The following is a description of a gene set: Human Gene Set: GSE41176_WT_VS_TAK1_KO_UNSTIM_BCELL_UP The activation signaling of transcription factor nuclear factor-kB (NF-kB) plays central role for immune system. One of key kinase mediating this pathway is TAK1 in adaptive and innate immunity. However, role of TAK1 in B cell receptor signaling is still unclear. To know effects of TAK1-deletion on the gene expression induced by anti-IgM, we performed the time course analysis in comparison of wild type with TAK1-deleted splenic B cells. Genes up-regulated in B lymphocytes: wildtype versus MAP3K7. from publication Shinohara H, Behar M, Inoue K, Hiroshima M, Yasuda T, Nagashima T, Kimura S, Sanjo H, Maeda S, Yumoto N, Ki S, Akira S, Sako Y, Hoffmann A, Kurosaki T, Okada-Hatakeyama M (PMID 24833394) studied in species Homo sapiens, and this is the list of marker genes: TOM1L2, HOXA11, ADGRG1, PPP2CA, SEC14L3, NTRK1, SH3GL1, NDST4, PODXL, TJP2, SNCG, IP6K1 (inositol hexakisphosphate kinase 1), ARID5A, ACSL6, PCDHA6, MAP3K8, VAPB, SPRR1A, SZRD1, RPS14, PTGDS, ALCAM, SRPK3, TOE1, SRD5A2, BID, MUC2, UBE2H, SMS, DNAJC8, SIPA1L1, CAMP, RPL13, SNN, ECE1, INSIG1, PPP1R15A, BCL2A1, NPY4R, CALCOCO2, HLA-DQB2, MIA, ARFGAP3, TLK2 (tousled like kinase 2), KCNK7, CLK3 (CDC like kinase 3), NHERF4, TICAM1 (TIR domain containing adaptor molecule 1), LIME1, JAM3, CDC42EP2, BTG2, AMACR, AVP, STK19, NOP53, WTAP, ENDOD1, TRIB3, CNN1, BACH1, GPR37L1, ATF4, EREG, RNF2, GBP2, USP12, NR4A3 (NCBI Gene Id 8013), TNFAIP6, KMO (kynurenine 3-monooxygenase), PTTG2, LYPD3, AKT3, JOSD1, KANK1, CD69, SLC38A3, GMIP, TENT5C, TFF2, CHD5, PSEN1, EMD, ULBP2, ZNF394, RBP3, KLHL1, SPON2, NR4A1, ANKLE2 (NCBI Gene Id 23141), IST1, SF3B4, CLCN2, NFKB2, ZBTB17, TP53BP1, HOMER2, DNTT, TPSG1, DNASE1L2 (NCBI Gene Id 1775), SOD2, EDC3, ATF7IP, CHD4, RNF126P1, DNTTIP2, BMP6, TNFAIP8, TBX1, GCH1, ORC1, TPRA1, RRAGC, VASP, EFNA2, INCENP, DBN1 (drebrin 1), NRTN, ZFAND3 (NCBI Gene Id 60685), NINJ1, LILRA4, RAPGEF2, RELA, RBBP8, ZP2, AQP9, KBTBD2 (NCBI Gene Id 25948), TSPYL2, CLIC4, CDK17, CRYBB3, LTK, RAP2C (RAP2C, member of RAS oncogene family), FZD9, C10orf95, AKIRIN1, PCDHGA9, AEBP1, LINC00115, RAB5A, RPL35A, RPL24, RPS13, TAGLN2, CHST7, GJB5, SLC22A17, IGHG1, TNIP2, KHNYN, DNAJB5, TNFRSF1B, ADRA1B, LY6D, HRH3, PHGDH, NR5A1, BRAP, TRA2B, NAB2, NAMPT, LOXL1, ADH1A, RHCG, PTX3, FABP3, CYRIA, RASA3, STX11, LOXL3, B4GALNT1, HROB, RPL32, HLA-DQB1, MAFF, ZNF586, P2RX7, KHDRBS3, UBAP1, CCDC9 (NCBI Gene Id 26093), PRDM16, HMCES, CSNK1E, RPL30, ACSL1, HDAC11, RPLP1, RAP1B, RPS27, P2RY14, VRK3, KCNQ2, KIF25-AS1, MAPK6, CSNK1D, ICAM2, NUP98, TK1